Given this list of marker genes GPSM2, AKAP9, SIRT1, POLR2M, UVRAG, TBCCD1, SPOUT1, ARHGAP21, ASPM, PAFAH1B1, ATP2A1, here is a description of the gene set: species: Homo sapiens Human Gene Set: GOBP_MAINTENANCE_OF_ORGANELLE_LOCATION Any process in which an organelle is maintained in a specific location within a cell and prevented from moving elsewhere.